Given this list of marker genes Rps6kb1 (ribosomal protein S6 kinase, polypeptide 1), Afap1l1, Zdhhc3, Aff4, Ubn1, Usp3, Dlk1, S1pr1, Abhd4, Bahd1, Tmem200c, Smtn, Zfp592, Tra2b, Il5ra, Ppp3r1, Trak2, Plxna2, Ppp2r1b, Sec24c (SEC24 homolog C, COPII coat complex component), Lrrfip1, Ube2o, Col12a1, Phc2, Rhou, Fnip2, Tmem44, Parp6, Atp8a1, Grm5, Snx11, Mrps25, Sspn, Dpp10, Zfp868, Irs1, Trim8, Aplf, Ubqln4, Cabyr, Rhno1, Zfp607b (NCBI Gene Id 112415), D430019H16Rik, Vdac1, Nxt2, Cdk5rap3, Atxn1l, Nyap1, Gtf3c4 (NCBI Gene Id 99180), Nxph4, Ptpra, Sorbs3, Sec22c (NCBI Gene Id 382115), Golga1, Cdk4, Tmem204, Fkbp4, Rorc, Ms4a1, Tacc1, Pkp1, Dpy19l3, Efnb1, Zfp773, Fezf1, Zfp65, Acer3, Rnf122, Trp63, Fam199x, Adgrg6, Slc39a8, Slc13a1, Gdpd5, Tmprss11f, Timm9, Zfp59, Zfp629, Zfp644, Zfp516, Irag1, Eln, Adam10 (a disintegrin and metallopeptidase domain 10), Csnk1a1, Erbb4, Sgk1, Tafazzin, Hk2 (NCBI Gene Id 15277), Hnrnpu, Zfp626, Trf, Prx, Fat2, Ctsj, Fign, Ogfrl1, Derl1, Ttc1, Bhlhe41, Arpc5l, Inka2, Fto (NCBI Gene Id 26383), Opcml, Ddit4, Icmt, P2rx1, Lyplal1, Uba6, Arhgap27, Dcaf7, Htr1f, Styxl2, Pbp2, Tent5d, here is a description of the gene set: Genes predicted to be targets of miRBase v22 microRNA mmu_miR_1952 in miRDB v6.0 with MirTarget v4 prediction scores > 80 (high confidence targets). from publication Chen Y, Wang X (PMID 31504780) species: Mus musculus Mouse Gene Set: MIR_1952